Given this list of marker genes Tfap4, Cebpa, Nkx2-5, Zmynd15, Akap8l, H1f5, Smyd4, Sik1, Nr2c1, Camta2, Myocd, Mta3 (NCBI Gene Id 68548), Magea10, Dnmt3b, Bex6, Foxp3, Dact1 (dishevelled-binding antagonist of beta-catenin 1), Hes1, Bhlhe41, Lef1, Kctd21, Mecp2, Mier2, Dhx36, Hif1a, Pkn2, Nr2e1, Suds3, Mapk8, Kpna2rt, D7Ertd443e, Hr, Nipbl, Hoxa10, Pkn1, Wdtc1, Srf, Usf1, Six3, Mef2d, Parp1, Hdac6, Klf4, Prkn, Hnrnpd, Mier1, Magea9, Gli3, Phf6, Hsp90ab1, Insm1, Bcor, Cbx5, Rfxank, Tcf21, Xbp1, Mef2b, Hdac9, Hdac2, Cdc20, Brms1l, Mta2, Chd4, Mef2a, Gmnn, Nacc2, Hsp90aa1, Trp53, Nudt21, Rbbp4, Per2, Nrip1, Brms1, Runx2, Magea3, Magea2, Phb1, Hspa1b, Zbtb7b, Spi1, Atxn3, Bex4, Magea4, Runx3, Tal1, Rac1, Chd5, Mta1, Tbx2, Rara, Skor2, Hdac4, Ankrd1, Rela, Ankra2, Gcm1, Thap7, Hspa1a, Kat2b, Sp2, Ikzf3, Hdac1, Jdp2, Magea14, Dnmt1, Cebpb (CCAAT/enhancer binding protein beta), Magea8, Traf6, Kat2a, Lcor, Ncor1, Bcl3, Hic1, Ncor2, Kpna2, Twist1, Cry1, Zfp932 (zinc finger protein 932), Satb2, Ywhab, Sp1, H1f4, Magea5, Hdac10, Ddx20, Ywhae, Hey2, Smg5, Mier3, Lpin1, Mef2c, Sirt2, Ccnd1, Hdac3, Akap8, Cir1, Znhit1, Nkx3-1, Hdac5, Rad9a, Sfpq, Bltp3a, here is a description of the gene set: Mouse Gene Set: GOMF_HISTONE_DEACETYLASE_BINDING studied in species Mus musculus Binding to histone deacetylase.